The following is a description of a gene set: Genes predicted to be targets of miRBase v22 microRNA hsa-miR-2053 in miRDB v6.0 with MirTarget v4 prediction scores > 80 (high confidence targets). studied in species Homo sapiens from publication Chen Y, Wang X (PMID 31504780) Human Gene Set: MIR2053, and this is the list of marker genes: FMNL2, GTF2H5, GTF2A1, THAP1, ANKRD20A4P, NLK (nemo like kinase), CHRNE (cholinergic receptor nicotinic epsilon subunit), DMD, DEPTOR, PLCL1, CEP152, NAV1 (neuron navigator 1), VEGFA, PCMTD2, APPL1 (adaptor protein, phosphotyrosine interacting with PH domain and leucine zipper 1), ABTB2, E2F5, STRBP, DYNLT3, AKR1D1, DENND5A, CREB1, ZFAND6, ARHGEF10, OR2L13, LMO4, PIWIL1, CAVIN2, PTPRZ1 (NCBI Gene Id 7983), SLAIN1, SCEL, PUM1, PPP3CA, SPOPL, CDK2AP1 (NCBI Gene Id 8099), VTI1A, CREBL2, SDHB, PLEKHG7, CFAP58, ABCA10, SMG1, GPATCH2, OPRM1, ACVR2B (NCBI Gene Id 93), TBX18, FAM13B, STIM2, ZDHHC17, ACSM5, TGFBR1, DBX2, WDR75, COPG2, RAB22A, MTSS1, VWC2, CLIP3, SH2D4B, ITGBL1, ZNF614, CS, SGCZ, CLCF1, TMEM267, LAMP2 (lysosomal associated membrane protein 2), DNAJC10, ANGPTL5, GABARAPL2, RBM17, EPHA7, DIAPH2, FRMD5, MPDZ, GRM1, ZNF184, ERICH2, PDCD10, RDX, ZEB1, CT62, CALCRL, RAP1B, MTM1, PPM1A, SRSF7 (NCBI Gene Id 87459), SLC2A10, ADAMTS14, CISD2, RAB21, ANKRD20A3P, PCDH9, USP38, ANAPC7 (anaphase promoting complex subunit 7), DISC1, CHM, NUP160, POC1B, PDE4D, NPAS2, ALDH1L2, DCP1B, TNFAIP6, CENPE, MOB4, MAPK13, B4GAT1, NUP153, PTPRQ, PLPPR4, MTFR1, UACA, PTBP2, BRWD3, CEPT1, ADAM28, GUCY1B1, EVI5, ADAMTS5, TAOK1, MSH4, AGPAT3, DRAM1, TPRKB, G6PC2, NABP1, ZC3H13, PON2, RAB10, LMNB1, C2CD6, COL14A1, PRLR, PCBP3, ZFP82, RARB, KCND2, PTAR1, TAF12, USP13, ANGEL2, PUM2, KCNJ13, MCEE, DHRS4, NR4A3 (nuclear receptor subfamily 4 group A member 3), USP46, GLRX3, SLITRK3, EAF2, LIN7A, ANKRD20A2P, ZNF529, RFTN2, CLUL1, PIBF1, CNTRL, KIAA1143, SPRYD7, EML1, LILRB4, SERPINB8, UBXN4, GCLC, A1CF, ARHGAP35, KIAA0408, MSTN, LANCL1, RETREG1, SNX13, TCEAL9 (transcription elongation factor A like 9), LRP8, ANKRD20A1, LRRTM3, GTDC1, PILRA